The following is a description of a gene set: Mouse genes annotated to increased pituitary adenoma incidence (MP:0002041) retrieved from the Mouse Genome Informatics database via MouseMine from publication Motenko H, Neuhauser SB, O'Keefe M, Richardson JE (PMID 26092688) studied in species Mus musculus Mouse Gene Set: MP_INCREASED_PITUITARY_ADENOMA_INCIDENCE, and this is the list of marker genes: Prdm2 (PR domain containing 2, with ZNF domain), Mdm2, Nf2, Rint1, Rb1, Aip, Brip1, Prl, Cdkn2c, Helq, Cdkn1b, Men1, Thrb, Pomc, Drd2